Given this list of marker genes AKT3, EGFR, MAPKAP1, MTOR, AKT2, AKT1, RPL11, TP53 (NCBI Gene Id 7157), RIOK1, RICTOR, MLST8, PIK3CA, PTEN, RIOK2, FOXO3, here is a description of the gene set: Human Gene Set: WP_RIOK1_AND_RIOK2_IN_EGFR_AND_PI3KMEDIATED_TUMORIGENESIS species: Homo sapiens RIOK1 and RIOK2 in EGFR- and PI3K-mediated tumorigenesis